Given this list of marker genes HAMP, HYOU1, TAF6, TICAM1, GGT1, TMEM160, C4BPB, TBC1D17, CHPF, HSD11B1L, TMEM63B, LIMK1, SNU13, OGFOD3, ABCA1, RPL10A, ANAPC15, HYAL2, SLC39A4, NOC4L, AGRN, SLC39A3, MOGS, YDJC, MRPL11, PXMP2, METRNL, SREBF1, ZGPAT, FAM219A, SLC43A3, RAI1, PNPLA7, PALD1, PAFAH1B3, CPSF2, UQCC3, GNL3L, IL9, PLEKHN1, ZNRD2-DT, COG5, here is a description of the gene set: from publication Hoft DF, Xia M, Zhang GL, Blazevic A, Tennant J, Kaplan C, Matuschak G, Dube TJ, Hill H, Schlesinger LS, Andersen PL, Brusic V (PMID 28853442) Human Gene Set: HOFT_CD4_POSITIVE_ALPHA_BETA_MEMORY_T_CELL_BCG_VACCINE_AGE_18_45YO_ID_56D_TOP_100_DEG_AFTER_IN_VITRO_RE_STIMULATION_UP studied in species Homo sapiens Genes up-regulated in CD4-positive, alpha-beta memory T cell 56d vs 0d in adults (18-45) after exposure to BCG vaccine, time point 56D, administered ID (intradermal). Comment: top 100 most differentially expressed genes comparing Day 0 and Day 56 responses after in vitro re-stimulation with BCG-infected autologous dendritic cells Protective efficacy of Bacillus Calmette-Guerin (BCG) may be affected by the methods and routes of vaccine administration. We have studied the safety and immunogenicity of oral (PO) and/or intradermal (ID) administration of BCG in healthy human subjects. No major safety concerns were detected in the 68 healthy adults vaccinated with PO and/or ID BCG. Although both PO and ID BCG could induce systemic Th1 responses capable of IFN-gamma production, ID BCG more strongly induced systemic Th1 responses. In contrast, stronger mucosal responses (TB-specific secretory IgA and bronchoalveolar lavage T cells) were induced by PO BCG vaccination. To generate preliminary data comparing the early gene signatures induced by mucosal and systemic BCG vaccination, CD4<sup>+</sup> memory T cells were isolated from subsets of BCG vaccinated subjects pre- (Day 0) and post-vaccination (Days 7 and 56), rested or stimulated with BCG infected dendritic cells, and then studied by Illumina BeadArray transcriptomal analysis. Notably, distinct gene expression profiles were identified both on Day 7 and Day 56 comparing the PO and ID BCG vaccinated groups by GSEA analysis. Future correlation analyses between specific gene expression patterns and distinct mucosal and systemic immune responses induced will be highly informative for TB vaccine development.